Given this list of marker genes Slc22a2, Slc22a1, Abcb1a, Abcg2, Abcc1, Abcb1b, Abcg3, Abcc2, here is a description of the gene set: Mouse Gene Set: GOBP_XENOBIOTIC_TRANSPORT_ACROSS_BLOOD_BRAIN_BARRIER The directed movement of a xenobiotic through the blood-brain barrier. species: Mus musculus